Given this list of marker genes Cdkn2aip, Ybx1, Spata4, Selp, Smim10l1, Themis, Slc20a1, Micu2, Foxf2, Ube2e3, Tnrc6b, Rnase1, Yrdc, Gpatch2, Pde2a, Nudt4, Hmmr, Camkv, Gdf6, Txlng, Zbtb26, Thoc2, Zfp472, Pitpnm3, Nrarp, Hspa5, Eif4g2, Hdac9, Cep76, Dzip1, Auh, Rfng, Zmym4, Lca5, Zfp975, Olfm3, B020004C17Rik, Lzts3 (leucine zipper, putative tumor suppressor family member 3), Lingo2, Clec12b, Nsa2, here is a description of the gene set: Mouse Gene Set: MIR_1193_5P_MIR_379_5P species: Mus musculus from publication Chen Y, Wang X (PMID 31504780) Genes predicted to be targets of miRBase v22 microRNA mmu_miR_1193_5p, mmu_miR_379_5p in miRDB v6.0 with MirTarget v4 prediction scores > 80 (high confidence targets).